Given this list of marker genes ANAPC16, CTDSP2, HSPD1, HNRNPA3P1, MDH1, CGGBP1, MAT2B, LBH, PPP1CC, SPTBN1, IARS1, SUMO1, CMTM6 (NCBI Gene Id 55487), SERBP1, LRRC8D, GTF3A, ATP6V1A, NCOA3, UBE2E1, here is a description of the gene set: Adult T-cell leukemia (ATL) is an intractable malignancy of CD4+ T cells that is etiologically associated with infection by human T-cell leukemia virus-type I. Most individuals in the chronic stage of ATL eventually undergo progression to a highly aggressive acute stage. To clarify the mechanism responsible for this stage progression, we isolated CD4+ cells from individuals in the chronic (n=19) or acute (n=22) stages of ATL and subjected them to profiling of gene expression with DNA microarrays containing >44,000 probe sets. Changes in chromosome copy number were also examined for 24 cell specimens with the use of microarrays harboring approximately 50,000 probe sets. Stage-dependent changes in gene expression profile and chromosome copy number were apparent. Furthermore, expression of the gene for MET, a receptor tyrosine kinase for hepatocyte growth factor (HGF), was shown to be specific to the acute stage of ATL, and the plasma concentration of HGF was increased in individuals in either the acute or chronic stage. HGF induced proliferation of a MET-positive ATL cell line, and this effect was blocked by antibodies to HGF. The HGF-MET signaling pathway is thus a potential therapeutic target for ATL. Human Gene Set: CHOI_ATL_CHRONIC_VS_ACUTE_DN species: Homo sapiens Genes down-regulated in adult T-cell leukemia (ATL), chronic vs acute clinical condition. from publication Choi YL, Tsukasaki K, O'Neill MC, Yamada Y, Onimaru Y, Matsumoto K, Ohashi J, Yamashita Y, Tsutsumi S, Kaneda R, Takada S, Aburatani H, Kamihira S, Nakamura T, Tomonaga M, Mano H (PMID 16909099)